The following is a description of a gene set: from publication Zwang Y, Sas-Chen A, Drier Y, Shay T, Avraham R, Lauriola M, Shema E, Lidor-Nili E, Jacob-Hirsch J, Amariglio N, Lu Y, Mills GB, Rechavi G, Oren M, Domany E, Yarden Y (PMID 21596316) Human Gene Set: ZWANG_TRANSIENTLY_UP_BY_2ND_EGF_PULSE_ONLY Genes transiently induced only by the second pulse of EGF in 184A1 cells (mammary epithelium). Normal cells require continuous exposure to growth factors in order to cross a restriction point and commit to cell-cycle progression. This can be replaced by two short, appropriately spaced pulses of growth factors, where the first pulse primes a process, which is completed by the second pulse, and enables restriction point crossing. Through integration of comprehensive proteomic and transcriptomic analyses of each pulse, we identified three processes that regulate restriction point crossing: (1) The first pulse induces essential metabolic enzymes and activates p53-dependent restraining processes. (2) The second pulse eliminates, via the PI3K/AKT pathway, the suppressive action of p53, as well as (3) sets an ERK-EGR1 threshold mechanism, which digitizes graded external signals into an all-or-none decision obligatory for S phase entry. Together, our findings uncover two gating mechanisms, which ensure that cells ignore fortuitous growth factors and undergo proliferation only in response to consistent mitogenic signals. studied in species Homo sapiens, and this is the list of marker genes: LLCFC1, TNFRSF1B, ADAMDEC1, LRRN1, DGKZ, AZU1, TGFB1I1, FAM136A, COL27A1, CSPG4P2Y, RAPH1 (Ras association (RalGDS/AF-6) and pleckstrin homology domains 1), TBC1D29P, GBP7, ZNF662, WFDC1, OR52B6, TNNT2, IL2RG, ZBTB12, KIAA0825, DPYSL5, TBC1D22A-AS1, TNNC2, RN7SL278P, MIR103A1, EEF1B2, OR51F2 (olfactory receptor family 51 subfamily F member 2), GRIN2C, GABRR1, CD302, GFOD1, AMER1, LZTS3, ONECUT1, SLC25A37, HBG1, OR6P1, CBY2, TUBB2A, RELT, KIR2DS3, RNVU1-17, SERTAD4 (SERTA domain containing 4), CACNA1S (NCBI Gene Id 779), DNAJB4, SCIN, CXCR6, RN7SKP16, ACHE, LINC00526, TCP10L, KLK15, LYZL4, DPPA3P1, RN7SL416P, BSPRY, RNA5SP443, FZD1 (NCBI Gene Id 8321), CES1P1 (carboxylesterase 1 pseudogene 1), ZNF711, RNA5SP399, FRMPD4, RPRM, TOP3A, BTBD8, ADAMTSL1, CSF2RA, FFAR3, ZNF579, SLC39A8, KCNG1 (potassium voltage-gated channel modifier subfamily G member 1), PLEKHG4B, BRINP2, EML6, SIX5, RNU6-57P, PM20D1, LRRC32, LINC03124, OR2A14, PDE7B, NPAP1P9, NXF5, LINC01138, CDK5R2, MFSD6L, CDKN2D, MRO, ZNF430, ZNF550, RBMY1A1, SLC17A7, TMT1B, NUP43, CRNN, TEX56P, FREM2, WNT9A, RN7SL647P, RNY4P36, SHH, SOX18, CD300LG, TEX13A, ASPDH, POM121L1P, FSIP2, CREB3L1, ZNF295-AS1, KRT3, HSF5, EMC3, H1-7, SHC4, ACOXL, CCDC148, ZIK1, PPP1R14A, MSI1, RNU1-42P, SFMBT1, TRIB2, ADRA1B, POU2F3, LINC02538, PPP3R2 (NCBI Gene Id 5535), CENPT, FBXO41, MIR154, DPPA5P4, TLX2, MIR323B, RNA5SP84, TGM6, MAGEA5P, LIPI (NCBI Gene Id 375108), BCORL1, FOXG1, LINC01101, SNORA8, PPP1R16B, SCIMP, NUDT9P1, NNMT, ENSG00000212604, SLC9A3, NGEF, RNF149, BIRC7, CACNA1C, GBA3, SLC41A1, UNC93B3, RNU1-107P, RNU11, GRHL1, PLCXD2, TMCC3 (NCBI Gene Id 57458), GLDN, FPGS, SYT15, FAM184B, RN7SKP74, ACSM3, ENSG00000221043 (Small nucleolar RNA U3), RNA5SP403, MIR208A, RNU6-233P, FMOD, RHEBL1, BHLHA9, PROSER3, RNA5SP133, CACNA2D1, ENSG00000272195, CNGB1, ABCC4, SNORD30, RBBP5, FRMPD2, FAM153A, ZNF593, SIGLEC17P, KCTD8, PRR32, DUSP29, GAR1, ME3, PAGE4, REX1BD, KRTAP2-1, CCDC187, SPANXA1, OR1G1, MS4A7, CHP2, SLC16A3, SLC1A2, MOCS1, OR14K1 (NCBI Gene Id 81452), RN7SL411P, TEKTIP1, ZNF497, LINC01657, ENSG00000207502, BMAL2, FAM201B (family with sequence similarity 201 member B), OC90, LINC00242, ACSS2, SNIP1, SLC28A3, TUSC1, EIF4A2, PAQR8, RNU6-818P, MCF2L, RNA5SP118, M1AP, CCND1, KRT73, CCDC167, TOX-DT, OR5BS1P, RAB7B, DRC7, UBALD1, NOS2P1, POU5F2, PATE2, ADGRE3, DNASE1L3, CD79A, RGS9, FGF22, DUSP8, RFX6, MCHR1, TPRG1, TSPAN16, SLC4A9, ENTPD8, RNU4-80P, LINC02961, OR6C65, WNT8A, MT-TS1, KPNA7, ENSG00000202233, TAS2R60, LIM2, CBX8, SPIN2A, MOV10L1, ARSH, STAC3, UNC80, PAX6, RN7SL530P, ANKS1B, RAB20, ZNF826P, KCNMB3P1, OR4C15, C11orf40, RPS12P23, B3GNT3, ICAM2, MTAP (methylthioadenosine phosphorylase), BSPH1, TLL2, RIMBP3, C17orf58, RN7SL655P, PDZRN4, CACNA1A, STOX2, GCNT1, OR13D3P, EBF1, SPRY3, LINC00173, FMO4, GPR63, ANKRD13B, GOLGA6B, WIPF3, NFATC4, TSSK1B, CORO2B, METTL21C, OR2N1P, RNU6-906P, IDO2, LINC00683, CD48, RPL21, ATCAY, BRCA2, RN7SL269P, DNAH6, MIRLET7F2, RN7SKP37, COL22A1, PCDH10, DDX60L, OR1E2, RNA5SP28, IL27RA, IL37, LMTK3, OR10H5, ZNF518B, LCE1F, SAA3P, TNFAIP8, SAMD5, ZNF609, RND1, KCNMB1, ZNF491, CRB2 (NCBI Gene Id 286204), DNAJB5, AQP8, FCER2, GPR171, KEL, RNF166, NLRP12, ATP6V1G3, MIR31, TMEM234, TTTY5, HMGA2, ANKRD33B, SRPK3, UPK1A, SLITRK4, IHH, CSF1R, HSPA12B, MEP1A, NXNL2, DUSP5P1, UGT3A2, DNMT3A, GUCY2F, C11orf68, EMILIN3, KRTAP5-3, LYG2, SAMD9, MAPK15, IL32, RN7SL228P, PRRX2, CCDC175, HGD, TNFRSF9, OR3A4P, CERS3, ENSG00000292415, ZNF697, CHST12, OSBP2, GABRB3, RNF32, PGAM2, RNU1-58P, SMYD1, DRC1, TM6SF1, SIGLEC5, LGALS13 (NCBI Gene Id 29124), CLLU1-AS1, SAC3D1, KCNH6, SACS, GPAT3, RBBP8NL, SRY, DDX3Y, FGF20, UCK1, LINC03025, OR1N1, KRT8P11, MALL, SPAG4, RNVU1-34, CEP72-DT, RNU6-340P, FXYD1, CYB5R2, GGTLC1, CRIP1, LETM2, POU2F2, GJC2, LINC00851, ENPP7, DIRAS1, SYDE2, ARID5A, CPA4, C1QTNF2, INSYN2A, BRIP1, LINC01512, DUS3L, PKD2L2, HSFX2, APBB2, TFAP2D, CCL3, LIPH, OR7E13P (NCBI Gene Id 26631), SULT1A1, C11orf24, CLCNKA, LINC00917, IL17D, F2 (NCBI Gene Id 14061), C9, DNAH10, EDN3, PREB, ANO3, RNU6-874P, APOBR, CHST6, GNG2, CTSE, MACF1 (NCBI Gene Id 649183), ABCB5, SMIM23, ACSM1, LINC01287, LINC00937, TEAD2, OR6N1, PCBP3, PLPPR3, LPCAT4, DKC1, MYADML, PHOX2A, HSPA6, C6orf118, GPR26, ALG1 (NCBI Gene Id 56052), MIR503HG, NOP56, RRS1, DKK4, MAP1LC3C, TMEM207, PIMREGP2, H2BW2, ZNF385C, CCDC60, NEUROD2, RNU6-1167P, MICAL2, ENSG00000212321, AGAP2, ALKBH8, HEMGN, CMTM3, TMPRSS15, IRGC, TTLL8, DOT1L, DNAAF1, UPB1, MYO7B, DOK7, KASH5, ENSG00000269155, CTSG, ENSG00000201957, PGA5, SLC30A10, EIF4A1P2, CD52, PREX2, SLC22A16, SMAGP, OBP2A, MS4A4A, THSD7A, RN7SL288P, TAT, ZBTB1, PPRC1, PTPRCAP, RNA5SP440, RESP18, WDR82, PHYHIP, MYOZ3, RN7SL571P, RASIP1, ZNF503-AS2, SLC36A3, KLHL30-AS1, CLIP2, BRINP1, TLR4, RNASE13, CCDC198, SRL, JAKMIP1, RN7SL473P, SHF, SLC10A1, CD2, TRPC3, ESPN, CLEC20A, GCG, PODN, PAK3, DYNLT4, SLC38A4, TMEM38B, SLITRK6, N4BP2, HMGB3P1 (high mobility group box 3 pseudogene 1), RGL3, DSG4, TSPAN12, GPR22, CYSLTR2, MLX, CAPN9, DEFB109A, LAPTM5, KIR3DX1, CT45A3 (NCBI Gene Id 441520), PHLDB3, CCR3, APCS, ENSG00000221461, LCN12, DKK1, RNU6-925P, WNT7B (Wnt family member 7B), PRDM1, C15orf48, C16orf78, RNU1-62P, CLIC5 (NCBI Gene Id 53405), TLCD3A, VMO1, MUC16, RAX2, MIR202, APOF (apolipoprotein F), IRF7, TLDC2 (NCBI Gene Id 343574), CACNG1, FAIM2 (NCBI Gene Id 26294), USP35, RNFT1, CD248, KLF17, OR7D1P, FBLN2, LINC00477, TNFSF13B, RDH13, TXNDC8, HDAC11, STEAP1, MYL7, PIK3CD-AS1, RN7SKP207, RNA5SP483, RNA5SP52, ALKAL2, NOG, RN7SL260P, LCP2, PRSS42P, ANKRD53, PAGE5, OASL, RN7SKP29, KLK13, OR10P1 (olfactory receptor family 10 subfamily P member 1), TSPAN5, FCHSD1, RN7SL384P, SSPN, CBLN1, PAPOLB, CCNP, KCNK7, SYT10, PRSS57, TTLL6, ZNF628, PRR34, GABRD, PRAMEF10, LINC02901, MIEF2, ABCB1, LINC00686, CNR2, PPM1H, LONRF1, MYH2, RNA5SP493, MRGPRG-AS1, KIAA1614, GLCE, KRT16P2, RPS2P35, GPER1, SCUBE1, KRT71, WFIKKN2, DEFB125, CBS, RASD2, TBC1D27P, TMEM130, RNU6-726P, FAM20C, SEC14L5, FLT1, R3HDM4, ZFPM1, KRT17P5, ZFYVE28, UBL4A, NFAM1, KLK2, RN7SL801P, RN7SL846P, ARSJ, PURG, FUOM, KATNBL1, STARD9, OR11H4, DSCAML1, ENSG00000281863, CHD7, RN7SL837P, ACRBP, LEF1, RBAK, RND2, TEKTL1, PCDHA2, GSTM5P1, PRRT1, TRNT1, CLDN5, PRAMEF5, ADPRS, FNDC1, OR2J3, OR1P1, SLC51B, SWSAP1, FAM161B, RN7SKP139, WTIP, SLC6A7, ABHD17A, GPR137B, C11orf21, DLX3, OTUD7A, RN7SKP26, TAAR6, ADRA2C, RN7SKP208, ENSG00000267882, PVALEF, RN7SL666P, LRRC38, WDR86, RBPMS2, DPEP2, ACOXL-AS1, CATSPERG, PHYHIPL, NEUROG3, MFSD12, UGDH, PRSS21, CLEC3A, SLC39A13, NLGN2, TNMD, SNAI3, RN7SKP281, TNFAIP6, TSGA10IP, SOWAHB, RP1, KIR2DP1, CRYGN, FAXC, LCN15 (lipocalin 15), GUCA2A, ACTL6B (actin like 6B), ZNF500, RNU6ATAC15P, OR52N1, C11orf42, ZNF618, MYEOV, GNAI3, FAM217A, ANKRD37, GPR158, OR10A4, DGCR5, PROX1, SNORA16B, PLEKHG2, MBD3L2, MEFV, RNY4P13, POTEH, LST1, RAET1E, RNA5SP525, UBQLNL, ATP2B1, ULBP2, MYO1D, PAGE3, GALNT17 (NCBI Gene Id 94294), ENSG00000212551 (Small nucleolar RNA U3), PHC2, LINC00482, OR4D5, SCAMP4, MIR3667HG, RNA5SP344, CCR5, CTU1, HID1, NKD1, CCKAR, HSP90AA2P, PERM1, KRT80, IGLV6-57, ZDHHC23, LCE3C, SYT7, OR4C12, RNU6-571P (RNA, U6 small nuclear 571, pseudogene), BLOC1S3 (NCBI Gene Id 388552), RN7SL820P, SPATA31C1, BIN2, KCNJ3, NEU4, RNU1-75P, TENM1, CCDC110, HMCN1, PI16, SNORD38D, FERD3L, RN7SKP286 (NCBI Gene Id 106481822), TESK1, KRT18P55, RNA5SP469, TTBK2 (NCBI Gene Id 26044), OR56B4, IP6K3, CACNG6 (calcium voltage-gated channel auxiliary subunit gamma 6), RN7SL63P, SPATA31A7, USP43 (NCBI Gene Id 124739), TMSB4XP2, CFAP184, EMILIN1, NR5A2, CRX, GABRA1, ELF5, GARIN5B, CYP2A6, RNU6-618P, GLOD5, MSMB, DEFB103B, DRC3, PRM3, RBP2, CLCA1, EBF2, P2RX2, CIMIP5, TRPM6, PPIAP35, MSH5, INSYN1, HLA-DPA2, RCN3, LINGO1 (NCBI Gene Id 84894), SPEM2, RNA5SP234, BRSK1, RN7SKP165, DPF3, HOXA10, YIF1B, NTSR2, RNU6-608P, CAPRIN2, IL12RB2, RPL10P12, SCGB1A1, ADORA2A, UCKL1, WFDC6, ISLR2, BMP5, SNHG15, CCKBR, OPRD1, GIPC3, PDGFD, CLEC4G, TSKS, GPR83, RCAN2, GJB1, EFNA3, SPDYE3, LILRA2, RBP1, WDR43 (WD repeat domain 43), TLCD3B, RN7SL748P, SPIN3, RN7SL493P, C14orf93, INF2, TRIM59-IFT80, ATP6V0E2-AS1, TNNT3, RPS2P7, MAP3K14-AS1, RNU6ATAC33P, C1orf35, RNU1-88P, PNPO, KCNJ9, ZNF415, DPPA5, TMEM150A, DDX28, MSR1, KCNK10, CTRB1, FCN1, STPG4, TSPAN32, HSPA8, LCN9, CES1, HCG9, SEC24C, KPLCE, GPRIN2, RIMKLA, FRMPD1, SLC5A3, PHF13, RDH12, CBARP, FAM151A, NIBAN1, RNU6ATAC6P, XKR8 (NCBI Gene Id 86422), SLC8B1, ZBTB45, VSIG2, EIF4A1P13, SSU72L6, ING3, MB, PPP2R3A, KCNH3, ACOT6, GPR179, COL6A3, ITIH6, HOXD13, DANT2, MFAP4 (microfibril associated protein 4), RPH3A, CFHR1, OR51A2, EWSAT1 (Ewing sarcoma associated transcript 1), B4GALNT3, SLC26A8, SNORA70 (small nucleolar RNA, H/ACA box 70), KCNJ8, TBR1, GABRA3, TET3, OR10J1, RNA5SP265, CCDC142, ACTA2-AS1, RNU4-26P, SH3TC2, TRAF5, FOXC2, SLC25A34, AKAP3, C1orf216, CFAP141, MYRIP, UEVLD, WFDC2 (NCBI Gene Id 128489), SH2D1A, TESPA1, RN7SL74P, BPIFB4, ALDH1A2, C6orf47, TFF2, BMI1, OR9M1P, GRIA3, SP8, TNFSF12 (TNF superfamily member 12), FAM162B, GAL3ST3, DUSP6, TRIM67, ZMAT1, SNTG1, FOXJ1, CASKIN1, RNVU1-19, UBA6, TTC28-AS1, LOXL3, FHL1, BTNL9, CYSRT1 (cysteine rich tail 1), LRRC71, PRB3, MALT1, ZNF10, NES, RN7SKP213, ZC3H12D, ABHD16B, ZNF276, CNR1, IGSF5, CBLC, LINC00115, RNA5SP472, UBE2U, MRGPRD, SRRM3 (NCBI Gene Id 222183), ACADL, KRTAP10-8, SIRT1, C1QTNF8, IQSEC2, LILRB5, RN7SKP161, UCP2, CNGB3, EFNA2, KHDC3L, SNAP25, EBF3, RNA5SP174, FAM133A, KCNJ10, NPB, STAC2, ADGRG4, TEX15, DNM1P34, KLC2, EEPD1, ENSG00000202537, ASB6, GSTA2, RNA5SP264, TUBAL3, ZNF22-AS1, RNU6-1254P, PLEKHG7, FGF19, TCP10L3, DRD4, ZNF568, ENSG00000239096 (novel transcript), SHISA7, FAM50B, HEPN1, OR9G4, IRAG2, MROH2B, BRS3, HYDIN, RNU6ATAC42P, FREM3, FGF11, AMIGO2, CT75, ADRA2A, TRHDE-AS1, HBQ1, RN7SKP151, NOB1, GBP4, SNORA1B, PPIF, MAEL, CFAP65, ZMYND15, C1QL3, CNTN2, SIRPG, RN7SL307P, OBP2B, GRIA1, TGM2, DAB2, TMEM51-AS1, KRTAP10-1, RGS19, LINC02871, LINC00518, ASPN (NCBI Gene Id 54829), TPD52L2, CLDN9 (claudin 9), DDC-AS1, CEACAM6, CRACR2A, SUFU, PRKAR2B, CRYGC, ACSM2A, SHISAL1, TLR8, CRYGB, TIA1, PADI1, PDE5A, HMX2, RN7SL60P, RNU6-626P, RNF39, BAIAP2-DT (BAIAP2 divergent transcript), TEX55, C10orf90, RNA5SP240, HR, HOXD12, ORM1, LMOD2, NKX6-3, MANEAL, PDLIM2, ITGA5, MKRN3, CD58, OR2T1, PCDH12, OR6K6, ZNF487, SH2D4B, RNF227, ANKRD1, ANXA2R, COL6A2, PRDM14, ACTL9, RNA5SP191, ZPBP2, GFOD2, OR9I2P, ENSG00000206853, ADAM18, GJA8, GREM1, RBFOX3, ERICH6, RN7SL448P, CSF3, RN7SL538P, SHCBP1L, NEB, TRIM75, CCDC42, TYROBP, BCL2L2, COL28A1, SOX5, CBX1P5, RN7SL822P, TMEM8B, AGTR1, IRF4, JPH4, BAMBI, AGER, NDNF, OR2I1P, LOX, AK8, FAM74A1, CMTM5, UTP25, IL22, ANKRD34C, MDFI, MYBBP1A, PGPEP1L, ZNF804A, LINC00943, SPRED1, FLJ40288, RNVU1-22, RN7SL738P, TMEM222, TOR1AIP2, FGF17, FBXL7, OR2L13, RGS11, CXCR5, SCGB1D2, KALRN, TRIM61, NEXN-AS1, RNU105B (RNA, U105B small nucleolar), EPB41L3, CLDN14, MAP3K4, ANO5, IGSF10 (immunoglobulin superfamily member 10), LTK, RNU6-61P, CCDC181, IGKV1D-43, C11orf86, SHFL, TTTY10, PWWP2B, GOLGA8UP, SHROOM4, KCNJ2, SLC17A4, MPPED1, CATSPERE, ATP2B3, TNFRSF11A, HAS1, GP2, NANOS3, LINC03009, MAMSTR, FCAMR, CAMK2B, HPGDS, HPD, RASGEF1A, F2RL3, CACNA1F, RHOU, ADGRD1-AS1, MYOM3, KCNMB2, FRMD1, NBPF4, RNU6-272P, MESP2, SEC16B, NIFK, MIR128-2, CCN5, MAGEC2, GPR78, ATP13A4, CARD19, CRYBB3, COL5A3, TNS4 (tensin 4), SCGB1C1, LINC02073, ORAI2, LRRC3, COL14A1, TTC24 (tetratricopeptide repeat domain 24), ANKFN1, RN7SKP89, SLC39A10 (solute carrier family 39 member 10), KCNJ12, OR4D1, SYNGR4, PEBP4, NSUN7, LINC01446, OR1M1, ALLC, HPCAL1, SAMD9L, RN7SL39P, ANKRD45, GGNBP1, TCAF2, IL3, GABRB2, TDRD9, CHRNA9, KRTAP9-1, GLIS1, CEACAM3, SPATA31F3, PIP5KL1, AFDN-DT, MIR100HG, GAB4, KIR2DL1, CFAP206, F11, RAB43, OGDHL, PRAG1, WFDC11, PDLIM4, RNA5SP500, RN7SKP168, TYMP, TAAR3P, RNA5SP161, RINL, RNU7-35P, PODNL1, CLEC2A, POU3F4 (POU class 3 homeobox 4), VENTX, SCGB1D4, SEPTIN3, TERC, MAP7D2, NAT8L, CDH8, SNORD12C, LINC00272, MYL9, TMEM244, TMEM200B, TRAPPC14, SCART1, TNN, LRFN2 (leucine rich repeat and fibronectin type III domain containing 2), MTUS2, POTEE, PRDM4 (PR/SET domain 4), TCEAL3, CD300E, OR1L3, SLC22A11, OR7A17, HMGN2P20, NPC1, ENSG00000200063, NR1D1 (nuclear receptor subfamily 1 group D member 1), NGF, SPAG6, OR7A11P, VN1R10P, GSC, PSG6, TMEM145, BACH2, GJB3, OR2M5, NPY2R, GBX2, RPUSD1, TSSK4, OR10AC1, PLAGL2, FAM41C, MIRLET7E, RNA5SP321, FOXD4, ELOVL4, HPCA, TERB2, MIR134, VAX2, CHRNB1, HAS3 (NCBI Gene Id 3038), CD19, COL9A2, RN7SL42P, CYP4F11, KLRB1, RIMS1, TXNIP, SEMA4B, RN7SL38P, DELEC1, SLC17A9, MARK2P21, EID2B, H2BP1, TCP11, SLC4A7, L1CAM, PRR23B, OLFM1, SYNGR1, EIF4A1P3, HGFAC, RAB37, RN7SL564P, BTBD9, UPK3B, SCARA3, GEMIN5 (NCBI Gene Id 25929), RN7SL178P, PIWIL1, ICOS, KRTAP5-5, RN7SKP214, RIPOR2, ZNF775, TDRD5, CD207, KAZALD1, CEMP1, RBMS1, HSPD1P1, MAP3K4-AS1, GPSM3, XAGE2, ST20-AS1, SERPINB9, SLCO1A2, RNA5SP192, TSPAN11, CNGA1, IDO1, FAM27C, CNTD1, LY6G6D (NCBI Gene Id 58530), CLEC3B, WWTR1, CXXC4, OCRL, EFHD1, IFNW1, RSPH14, ESPNP, GPR4, UNC79, TOR1B, TPD52L3, RAB3A (NCBI Gene Id 96387), TEN1, SGIP1, PCDHA3, CFAP73 (cilia and flagella associated protein 73), PLA2G12AP1, SH2D3A, RN7SL336P, WDR36, TMEM270, LINC01559, CTAG2, IL4R, CARNMT1 (NCBI Gene Id 138199), P2RY4, TINAGL1, LCK, ZNF252P-AS1, MGAT4EP (NCBI Gene Id 641515), TUBB8, CATSPER1, ZPLD1, COL6A1, RNA5SP520, CDH23, GRIK1-AS1, ANGPTL7 (angiopoietin like 7), RNVU1-4, FOXN1, ZAN, CIB4, AMPD1, DNTT, OR2AE1, RNF208, TIAM2 (TIAM Rac1 associated GEF 2), TCHHL1, CELF4, ALDH1A1, TCTE1, RETN, OXCT2, SOX3, KRTAP3-2, P2RX1, ZSWIM2, ZNF398, IRF8, ODAD1, ZNF221, NMRK2, ARIH2OS, AQP12A, GGN, ELK3, TM4SF18, LINC02487, SALL3, HS3ST5, DDX25, SOHLH1, GRM8, CCDC83, SLC5A10, PTGS1 (prostaglandin-endoperoxide synthase 1), STYK1, ST8SIA6, RNVU1-33, STX12, TRIM64, TMEM82, RN7SL122P, OR13F1, PPARG, POU2AF1, GGT3P, WBP2NL, RN7SL221P, OR52A1, CELF6, RAG2, P2RX3, SASH3, SOX12, CORO2A, ZFR2, RNVU1-24, CRACD, ENSG00000280636, SORCS3 (sortilin related VPS10 domain containing receptor 3), SNTB1, GSTT1, DOCK8-AS1, RN7SKP144, SUN3, RNU2-63P, SNORA35, RNA5SP450, ADGRE5 (NCBI Gene Id 976), MPZ, C10orf95, EEIG2, EMILIN2, TMEM239, MIR106A, PDZD4, ADRA1D, POLR1B, PDE3B, ENSG00000201329 (NCBI Gene Id 124902100), MMEL1, RNU6-715P, SPANXN1, DIRAS3 (NCBI Gene Id 9077), PRSS50, SOCS1, NTF3 (NCBI Gene Id 4908), ENSG00000188897, MIR222, FAM177B, NLRP6 (NLR family pyrin domain containing 6), RNA5SP475, PIEZO2, ISX, SSBP3-AS1, PCDHB18P, IFFO1, HTR3B, RPL3, RNU6-335P, MGMT, CTHRC1 (collagen triple helix repeat containing 1), URB2, ENSG00000202268, CFAP47, ZNF781, MPO, RNA5SP79, AURKC, ABCA3, PCDH9, ZNF703, GML, CHAD, PTK6, RN7SL197P, RLN3, NAALADL1, GJC1, CCNQ, MYCNOS, NTM, HMGN1P31, CAND2, C1orf146 (NCBI Gene Id 388649), SPACA9, STUM, ZCWPW2, HSF4, ATRNL1, TRAIP, SLC35E3, NKX2-1, ITGA11, C4orf50, KLF14, SCRT2, OR51L1, DUSP2, TBXT, ERCC6, SLCO2A1, LNCEGFL7OS, CD200R1L, OR5H6, RPSA, ALOX15, UBASH3A, LCN1P1, LSP1, BCHE, IGHV1OR15-1, FGD6, ADAM11, ADGRE2, RNA5SP51, PWP2, FADS6, RNU6-989P, KCNF1, SARDH, PDE9A, KCNC1, RNU5F-1, NHSL2, NLRP9, FBXO24, DUSP9, IL6-AS1, LINC02610, MIER2, RN7SL432P, GSX1, ITIH1, GARIN5A, FLNC, ADGRD2, DLK1, LCE1C, PAX1, EFCC1, NEGR1, OR2K2, LCE1A, RN7SL322P (NCBI Gene Id 106479340), IRAK2, VNN1, LRRFIP1, RNA5SP514, CDH7, C2CD6, LINC00905, RN7SKP126, FMO5, RNA5SP294, RN7SL319P, S100A12 (S100 calcium binding protein A12), RNU6-728P, TNFAIP8L3, KCNB1, RN7SL715P, MIR205, TNP1, TMPRSS3, PALM3, ZNF771, FTH1P14, MAGI2 (membrane associated guanylate kinase, WW and PDZ domain containing 2), RN7SL229P, ZNF343, ZNF35, PAX2, ANK1, LAMA2, SNORD77B (NCBI Gene Id 109616982), CTDSP1, TINF2, CASP12, PRAMEF12, SLC2A5, RN7SKP106, RNF215, USP27X, TEKT5, EGR4, RN7SL684P, GCC2-AS1, GSTA3, LHX3, MIR150, TREML3P, SSX2IP, PLA2G4C, FEZF2, RNA5SP319, ANKLE1, RNU6-995P, TNFRSF21, IGF2BP2-AS1, ZNF750, HARS1, POM121L4P, SIRPD, ASPRV1, RNU1-15P, SNAPC2, TEX47 (NCBI Gene Id 219557), COL5A2, FBXO46, GLIPR2, CD83, BTNL3, HOXC9, ZC3HAV1L, CCR10, TRGV1, ZBP1, DMRT2, TLNRD1, LMO2, TIGD5, RNU12, CLCA3P (chloride channel accessory 3, pseudogene), POM121L15P, ST6GALNAC6, CSRNP3, KRT84, STK33, ZEB1, CEBPE, RNU4-75P, MIRLET7D, NMNAT2, MEGF6, ZNF517, RNU6-106P, SLC27A4, FEV, MIR182 (NCBI Gene Id 406958), MYO15B, RN7SL505P, NAXD-AS1, ZSWIM4, DUOXA1, OR10J5, SLC6A20, RNVU1-2, HSDL2, OR5M5P, STON1, IL34, OPALIN, DNAJA4, IL4, GPT (NCBI Gene Id 2875), PDE11A, CLIC6, RN7SKP230, C4orf17, ITGA7, CD8A, EYA1 (EYA transcriptional coactivator and phosphatase 1), TNFRSF12A, CKM, MFSD2A, TAFA3, RNU1-76P, CRIP1P4, TMEM262, MPIG6B, CIMIP1, CCNF, DUSP13B, WDR64, SIRPAP1, MAPT-AS1, MIR187, PROSER2, ZNF837, CIRBP-AS1 (CIRBP antisense RNA 1), GPR139, CPED1, PDE6G, PABIR3, DOC2B, PDSS1P1, LINC02897, EPHA1, GRID1, RN7SL394P, NYX, ENSG00000202517, VSTM2A, TNFSF11, GLRA4, ZNF831, GPRACR, TMEM196, ZNF676 (zinc finger protein 676), RIPPLY3, PDE4A, CYP2U1, RNU6-220P, MIR192, ESPL1, RNA5SP427, MIR149, BEX1, IFNGR2, OR8U3, CPA3, POP1, RNA5SP479, TPSD1, ZNF641, BAALC-AS2, ADAMTS10, RN7SKP8, HAPLN4, PHF21B, GOLGA6L2, EPX, HYI, ZNF48, NOTUM, GRIP2, PSORS1C1, FAM30A, ZNF114, GPRASP2, KLHL1, PGK2 (phosphoglycerate kinase 2), KRTAP10-12, RNA5SP275, IL1F10, RTL3 (retrotransposon Gag like 3), KLF1, SIGLEC27P, RNF222, A2M, PEX5L (NCBI Gene Id 51555), ASCL1, NPFFR2, C1QL4, DPP10, RNA5SP478, WSCD1, CASQ2, NPM2, ZNF677 (zinc finger protein 677), INO80C, CYP17A1, SLC15A3, DEFB110, FJX1, RNU5F-6P, TRPM1, CIITA, NCR1, GPR61, SLC12A4, PMP2, ASGR2, ABTB2, PRB4, DDAH1, ERN2, SLAMF8 (NCBI Gene Id 56833), MC4R, KCNV1, PKHD1L1, IDI2, UCN, MS4A8, LINC00574, LPL, CRYBA4, SYNGAP1, SARM1, OPN1MW, BAHCC1, MIR129-2, DPT, C9orf153, RPL34-DT, GPR182, RNU1-38P, MDK, LHX5, LINC02914, NYAP1, RN7SL118P (NCBI Gene Id 106480952), RN7SL692P, RNU6-454P, GLP2R, RNA5SP90, HRK, RNU1-112P, GUCY2D, NMS, LTBR, FANCE (NCBI Gene Id 2178), SNX18, APOA5, MIR153-2, NEK3, RN7SL181P, CLK4, GLIPR1L1, ACTRT1, TCF21, ADCY10, GJC3, MAK, C6orf141, RGS6, PCDHB15, DACT2, RN7SL479P, MELTF, NPHS1 (NCBI Gene Id 8183), GAS2L2, TRIML2, ATG16L1, UTS2R, CRYAA, TYR, RASA4, RN7SL165P, CYCSP39, KCNH8, HAPLN2, SNORD3P1, FAM138F, XAGE1B, RPL21P97, OTULINL, LGALS7, ATOSB, OR51J1, EIF4A1P11, SYNPR, WFDC5, RNA5SP117, ATG9B, MUC4, GALK1, ABCB4, CCDC38, TENM2, PCK1, FRMD5, PROK2, RNU6-87P, BPIFB9P, RNU11-5P, IGF2-AS, RITA1, TRAPPC13P1, MIR130B, RTBDN, GPR15, UBXN10, CLIC1P1, RPTN, URB1, PHACTR2, KCNE2, PALD1, OR5L1, THBS2, RBM38-AS1, TBX1, MAGEA9, ENSG00000202231, FHL3, ZSWIM9, AJM1, SOX15, CGN, ATXN7L2 (NCBI Gene Id 127002), NFE2, OR6S1, RNU1-19P, SSTR2, PKP2 (plakophilin 2), P2RY8, TAF1D, RNA5SP276, KCNA6, LINC00161, PNPLA1, POLA1, MORC4, ENSG00000207171, CALU, TPPP3, BSX (NCBI Gene Id 390259), NRXN1, CES5A, GRIK2, SLC39A12, RN7SL215P, GATA4, LYL1, RNVU1-8, ZBTB32, PORCN, RNU6-639P, MIR7-3HG (MIR7-3 host gene), LINC01755, RN7SKP257, COL3A1, OR10H3, DUXA, RN7SL344P, FAM81B